Given this list of marker genes Penk, Hcn1, Crhr1, Tmem74, Nr4a2, Zfp212, here is a description of the gene set: Mouse Gene Set: GOBP_GENERAL_ADAPTATION_SYNDROME studied in species Mus musculus General adaptation syndrome is the set of changes in various organ systems of the body, especially the pituitary-endocrine system, in response to a wide range of strong external stimuli, both physiological and psychological. It is described as having three stages: alarm reaction, where the body detects the external stimulus; adaptation, where the body engages defensive countermeasures against the stressor; and exhaustion, where the body begins to run out of defenses.